The following is a description of a gene set: Mouse Gene Set: REACTOME_TRANSLESION_SYNTHESIS_BY_Y_FAMILY_DNA_POLYMERASES_BYPASSES_LESIONS_ON_DNA_TEMPLATE Translesion synthesis by Y family DNA polymerases bypasses lesions on DNA template species: Mus musculus, and this is the list of marker genes: Rfc5, Pold2, Rev3l, Usp43, Pole2, Uba52, Rfc2, Mad2l2, Vcp, Poli, Rpa1, Rpa3, Rfc1, Rfc3, Uba52rt, Ufd1, Pcna, Pold3, Ube2l6, Nploc4, Ubb, Uba7, Rev1 (REV1, DNA directed polymerase), Pold1, Ubc, Pole, Pold4, Pclaf, Pole4, Polh, Rps27a, Rpa2, Rfc4, Sprtn, Usp10, Pole3, Isg15, Polk, Rchy1, Trim25 (NCBI Gene Id 22660)